Given this list of marker genes MC1R, SUFU, IGF2, SPRED2, KRAS, MRAS, FGFR2, XPC, RRAS, PRKAR1A, TYR, USF3, BLOC1S5, ERF (ETS2 repressor factor), ERCC2, PTCH1, CBL, HRAS, OCA2, AKT1, EED, FGFR3, SOX5, ZEB2, ALK, PTCH2, SDHB, RRAS2, PIK3CA, LZTR1, NFIX, SDHD, TNFRSF11A, ERCC4, KLLN (killin, p53 regulated DNA replication inhibitor), SUZ12 (NCBI Gene Id 23512), SOS2, PTPN11, RIT1, TAF4, RASA2, HPS1, RBM28, BRAF, RAF1, FKBP10, NRAS, PCGF2, ERCC3, SEC23B, THPO, CDH3, MPL, DDB2, FBN1, ERCC5 (NCBI Gene Id 2073), SOS1, TNFRSF11B, XPA, ROR2, CHRNA7, PDE4D, SPTBN1, SDHC, EZH2, TP63, COL3A1, PTEN, here is a description of the gene set: Melanocytic nevus Human Gene Set: HP_MELANOCYTIC_NEVUS A oval and round, colored (usually medium-to dark brown, reddish brown, or flesh colored) lesion. Typically, a melanocytic nevus is less than 6 mm in diameter, but may be much smaller or larger. studied in species Homo sapiens